Given this list of marker genes Nr3c2, Cav1, Agtrap, Fam114a1, Ppp3ca, Car2, Ahcyl1, Rock1, Rap1gds1, Slc26a6, Rock2, Ace, Agtr2, Agtr1a, Mas1, Ang2, Rac1, Camk2a, Agtr1b, Agt, Prkca, Src (Rous sarcoma oncogene, NCBI Gene Id 99351), Actn2, here is a description of the gene set: A G protein-coupled receptor signaling pathway initiated by angiotensin II binding to its receptor on the surface of a target cell, and ending with the regulation of a downstream cellular process, e.g. transcription. studied in species Mus musculus Mouse Gene Set: GOBP_ANGIOTENSIN_ACTIVATED_SIGNALING_PATHWAY